Given this list of marker genes SOX10, KITLG, EDNRB, TFAP2A, SNAI2, PAX3, TERT, WRN, PEPD, MITF, KIT, TYR, EDN3, LMNA, here is a description of the gene set: White forelock A triangular depigmented region of white hairs located in the anterior midline of the scalp. Human Gene Set: HP_WHITE_FORELOCK species: Homo sapiens